The following is a description of a gene set: from publication Amit I, Garber M, Chevrier N, Leite AP, Donner Y, Eisenhaure T, Guttman M, Grenier JK, Li W, Zuk O, Schubert LA, Birditt B, Shay T, Goren A, Zhang X, Smith Z, Deering R, McDonald RC, Cabili M, Bernstein BE, Rinn JL, Meissner A, Root DE, Hacohen N, Regev A (PMID 19729616) mouse primary BMDCs were stimulated with tlr ligands and gene expression changes were profiled on Affymetrix arrays Genes down-regulated in comparison of dendritic cells (DC) stimulated with CpG DNA (TLR9 agonist) at 12 h versus DC cells stimulated with Gardiquimod (TLR7 agonist) at 12 h. studied in species Homo sapiens Human Gene Set: GSE17721_CPG_VS_GARDIQUIMOD_12H_BMDC_DN, and this is the list of marker genes: NIN, SSR2, DMTN, TMX1, INPP5A, RPA3, PHTF2, UBE2B, ISCU, PTGR1, MLLT3, CEBPD, SIX1, S100A11, WBP2, IRF2, TOMM6, CABLES2, BBX, CERS2, TAF13, RNASET2, NUDCD2, CXCL2, MMP2, SERTAD3, PRXL2A, SOX4, INTS6, NDUFB8 (NCBI Gene Id 4714), WDR83OS, LMAN2, WFS1, DEGS1, MARK1, POLR2F, ANP32E, TMEM179B, ATP6V0B, AK4, SMYD5, CLEC5A, PRKRA, KCTD12, PPIL4, EGR2, TUBA4A, VEGFC, CARM1, NR2C1, RAPSN, ASH1L (ASH1 like histone lysine methyltransferase), UBE2E2, SQLE, CARMIL1, GADD45A, MRPL37, CACNA2D3, TANK, DAZAP2, NANP, THNSL1, METAP1, SLC1A2, PUM3 (pumilio RNA binding family member 3), LZTR1, GRIPAP1, MYO1B, SLC35B1, GZMM, CHKB (choline kinase beta, NCBI Gene Id 1120), TREM1, SLC16A8 (NCBI Gene Id 23539), SEPTIN9, APAF1, SH3BGRL3, RB1, CTPS1, SMAGP (small cell adhesion glycoprotein), NUTF2, D2HGDH, DACH1, MEST, PEX3, NT5DC3, RIOK2, IER3, SGK1, JKAMP, SLC22A4 (solute carrier family 22 member 4), HSPA1B, SUCLA2, PLXNA2, CLEC6A, SNRNP25, ANXA4, EMC6, CA4, SCRN3, HYPK, PHPT1, TMEM63A (NCBI Gene Id 9725), CAMK1D, C1R (complement C1r), CD33, RPA2, ZBTB20, BPNT1, GLG1, ZBTB11-AS1 (NCBI Gene Id 100009676), DOK2, LRRK2, TNNC2, MAPK8, LAPTM4B, BCL9, DUSP6, SPHK1, SHOC2, IL1RAP, CLEC4A, HSPA5, HCLS1 (NCBI Gene Id 3059), AXIN2, ABCC1, ERMP1, NENF, RIPOR2, ACTRT1, USP33, FGD6, H2AZ1, NADK, PSRC1, DDOST, C18orf32, LRPAP1, TMEM243, CLIP1, TMED10, SQOR, TFRC, MGST1, SUN1, NKIRAS1, HSD17B12, ZNF330, PKD1, SPRYD7, TFB1M, MTCH2, CNIH1, EMC9, ECHDC2, ALDH1A2, CYB5A, SATB2, CCDC77, KRTAP4-12, TSPAN31, NDUFA9, CPEB1, CLEC4D, SLC41A1, ABHD3, CPSF7, GLCCI1, SMIM14, EI24, PI16, VWA5A, COL5A1, MMP9, NCAPG2, RGCC, CRLF2, STEAP4, C4BPB, DEK, CXCL3, HCAR2, SPINT2, LRRC57, CCDC28A, HOXB13, GLUL (glutamate-ammonia ligase, NCBI Gene Id 2752), TRAPPC3, F5, IL9R, HES5, AKR7A2, ADGRA3, IFITM10, UROD, HIRA, TALDO1, SYNJ2, PIK3C2A, IL1B, CYB5R1